The following is a description of a gene set: species: Homo sapiens CNS development. Human Gene Set: MODULE_497, and this is the list of marker genes: SEMA3A, SLIT1, NNAT, SERPINI1, PCP4, NPAS1, NHLH1, SLC4A2, FOXG1, NPTX1, PTPRR, SNCA, GRIK1, TAC1, ADARB1, TFF1, KIAA0040, TBR1, ALX1, S100B, PDE6H, UGT8, GABRA5, RAD9A, ZIC1, GNAT1, NHLH2, PAX6, BAMBI